The following is a description of a gene set: species: Mus musculus Vitamin B2 (riboflavin) metabolism Mouse Gene Set: REACTOME_VITAMIN_B2_RIBOFLAVIN_METABOLISM, and this is the list of marker genes: Flad1, Rfk, Enpp1, Slc52a3, Acp5, Slc52a2